Given this list of marker genes THAP2, RABGAP1L, CTSS, HMCN1, ACADSB, AGGF1, ARMS2, PDZK1, SOCS6, STRN (striatin), GANC, PBX1, REEP3, TMED7, LRRTM2, UBE2G2, CAB39, FAM72B, PTAR1, TM4SF4, SFTPB, SESN1, SMAD1, CREB5, PRUNE2, NCOR2, MTFR1, SFRP1, MSI1, TRMT1L, VASH2, ENPP4 (ectonucleotide pyrophosphatase/phosphodiesterase 4), COBLL1, MEF2C, ACSL3, TMEM170B, FBXO32, SGPP1, UBA6, ZNF260, DIPK2A, SEMA3A, EDNRA, MAB21L1, JADE1, BNIP2, FOXC1, ZDHHC15, CNTLN, ARFGEF3, CCNG2, SLC4A10, ZNF93, RYR3, FBXO11, AKR7A2, DNAL1 (dynein axonemal light chain 1), CPOX, POSTN, CA2, CIMAP2, PLIN1, CPNE4, GOLGA1, PDCD4, RIPPLY3, SPINK13, SLC35D3, CNGA3, NFXL1, GDAP1, ZNF804A, LZTFL1, SACM1L, RBMS3, CCDC6, PDIA6, FNDC3B, BRWD3, NCK1 (NCK adaptor protein 1), FAM72D, ZNF425, LYRM7, ZGRF1, PRPF40A, GPX8, WAC, ZNF704, HOXB13, TSHZ2, USP46, TGFBR1, SNAP23, CLOCK, NEB, PEX1, ALDH6A1, SPRED1, TMEM106B, HYCC1, ZNF77, DCAF10 (DDB1 and CUL4 associated factor 10), POU2AF3, LANCL3, MGAT2, MED28, HIF1A (hypoxia inducible factor 1 subunit alpha), NANP, LIPT2-AS1, YES1, GOLGA5, SMIM43, ZNF678, POGZ, COQ10B, FAM72C, HYCC2, FZD3, SCML1, DOK6, GPATCH2L, STON1-GTF2A1L, LIN54, HADHB, GJA1, C1QTNF3, FAM204A, STXBP3, STXBP6, GTF2A1L, MXRA5, WDR7, PTCHD1, KCNH7, PGRMC2, PRKAR2A, PSD2, PPM1D, NUBP1, GFOD2, COX18, HACE1 (HECT domain and ankyrin repeat containing E3 ubiquitin protein ligase 1), BNC1, HIPK3, ARL14EP, LGALSL, GUCY1A2, BRWD1, LMBR1, RHOQ, EFCAB9, NAA50, TMEM53, SFXN1, SORBS1 (NCBI Gene Id 80057), KIAA0232, UXS1, RPS6KA6, FAM72A, CYCS, PLXDC2, ZBTB10, PMP2, RBM46, HNF4G, NFAT5, ABHD2, PID1, KCNIP4, TAP2, DCP1A, FZD4, KLF4, GALK2, SUCO, WNT16, DNAH14, PCDH18, IFI44, BCCIP, STK38L, RBM3, TRIM44, ELL2, CRELD2, ZNF37A (NCBI Gene Id 7587), TTC7B, RANBP17, ZNF449, KLF12, ZNF521, KCNG3, ABCD3, COX11, ZNRF2, CSTF2, ABCG2, CDH6, TXLNB, CYP3A5 (NCBI Gene Id 1577), GRIA1, MAP3K7, IKZF2 (IKAROS family zinc finger 2), C2orf69, TDRD7, VMA21, KLHL23, HLTF, PCNX1, CDK6, RC3H1, SMAD4, CTTN, RNF139, BLOC1S5, CLHC1, MFAP3, PPP1CC, HTR2C, SLC40A1, SCAMP1, B3GLCT, MMP28, GPR173, ADAMTSL3 (ADAMTS like 3), KIF13A, ARID2, ZFYVE26, CCR2, TPGS2, TSPAN12, KDM5B, THSD7A, H2AJ, UBR3, WARS2, IRS1, RHPN2, MCMBP, HS3ST5, KLHL14, ME2, SHTN1, RPL31, FBXL20, GDAP2, DYNC1LI2, NDEL1, IFT81, DTWD2, LIN28B, CACNA1H, TANC1, TAOK3, RSPO3, DNAAF9, EYA4, ZFP1, here is a description of the gene set: Human Gene Set: MIR4680_3P studied in species Homo sapiens Genes predicted to be targets of miRBase v22 microRNA hsa-miR-4680-3p in miRDB v6.0 with MirTarget v4 prediction scores > 80 (high confidence targets). from publication Chen Y, Wang X (PMID 31504780)